The following is a description of a gene set: Genes having at least one occurence of the motif CCATCCA in their 3' untranslated region. The motif represents putative target (that is, seed match) of human mature miRNA hsa-miR-432* (v7.1 miRBase). studied in species Homo sapiens Human Gene Set: CCATCCA_MIR432, and this is the list of marker genes: RAB10, ABCB9, CAPN6, GPM6A, COL11A1, BCORL1, ZGPAT, PTGIR, SMURF1, SPTBN4, KLHL18, LRP5L, PCDH10 (NCBI Gene Id 57575), ZNF775, SZT2, NTRK3, RAB5IF, NAA50, CXXC1, CLK2, ELK1, ACACA, SOX4, SLC22A7, GTF2I, CALN1, RPS6KA3, TM9SF3, RSBN1, KIAA1755, LRRC1, YPEL5, PCGF3, ERP29, IGF2BP2, FURIN, DYNLL1, PRKG1, RBCK1, AIRE, TOX4, LARP4B, SOX2, EXOC3L1, PPP1CB, SLC7A8, DUSP13B, TLK2, SIN3A, TMEM47, CAMTA1, CHD9, IDH3G, PPM1E, LEP, H3-3A, ADIPOR1, HECW2, ARID2